Given this list of marker genes IFI6, BOK, GOT1, ALB, SRC, HSH2D, FZD9, CAV3, BCL2, here is a description of the gene set: species: Homo sapiens Human Gene Set: GOBP_NEGATIVE_REGULATION_OF_MEMBRANE_DEPOLARIZATION Any process that stops, prevents or reduces the frequency, rate or extent of membrane depolarization.